The following is a description of a gene set: studied in species Homo sapiens Human Gene Set: E47_02 Genes having at least one occurrence of the motif NNNMRCAGGTGTTMNN in the regions spanning 4 kb centered on their transcription starting sites. This matches the TCF3 transcription factor binding site V$E47_02 (v7.4 TRANSFAC)., and this is the list of marker genes: NUMBL, HNF1B, MID1IP1, LYL1, CEL, MIEN1, BCL9, ERBB3, MGAT1, TPM2, MEF2C, GLI1, TICAM1, HDAC3, SLC7A11, PCDHA6, ERG, KLHL13, TMEM131L, ASIC4, FRMD5, MEIS2, SLITRK3, SNCAIP, RIMS2, PDE4B, PRKCQ, GNA12, TAL1, RAB33A, MYO18A, NPTX2 (NCBI Gene Id 95714), DRD3, CTDNEP1, DSCAML1, BICDL1, PCDHA10, PODXL, ZNF516-DT, NCDN, MLLT6, FOXI1, AIG1, MYL11, C6orf62, DMPK, NGFR, CPB1, AFF3, USP46, KCNN2, BCL2L1, ZNF532, SLC9A7, NDUFAF3, WDR6, CAVIN2, HMGN2, YIPF6, MAPK12, GIT1, MEF2D, MRTFA, ELAVL2, CNTN5, ASIC2, BZW2, S1PR1, CNTN6, OR10J1, RAPGEFL1, DENND1B, UBXN10, LSR, MMP16, KCNA4, AP4S1 (NCBI Gene Id 11154), MED26, HDAC9, PADI4, TTN, TENT5C, CPNE1, BTBD3, CELF4, TRAM1, THRA, PCM1, MEGF8, FGF11, NPAS2, PPTC7, APOBEC4, JMJD1C, PLEKHB1, LRRN3, GABRE, ESRP2, IRF1, RWDD2A, ARID5A, HES6, FGD4, NAA15, SYTL2, RHOBTB1, LMO2, GATM, WDR81 (NCBI Gene Id 780925), CUEDC1, EHD4, TPI1, CD40LG, FAM83H, BNC2, ARHGAP44, PTCHD1, MPPED2, ASXL2, DALRD3, GALR3, HSPB3 (NCBI Gene Id 8988), PURA, PNMA1, ARSG, GRIA1, SHISA7, HAPLN2, HOXA7, PPP2R2B, ABTB3, DUSP9, DGKA, FGF13, CCN3, ELP5, KMT2E, AMPH, KLHL1, PYM1, ART1, RELL2, CDH7 (cadherin 7), CHD6, FUT8, PARD6A, ZNF710 (NCBI Gene Id 374655), SEMA4G, TRAPPC13, TNFSF13, TSSK2, TTC22, PGM3, DSCAM, EPHB6, ARMCX2, CARTPT, STRN3 (NCBI Gene Id 29971), CEP41, NPAS4, R3HDM1, FRMD4A, STK3, NSG2, ALX3, SHOX2, ATOH7, WFIKKN2, PSMD3 (NCBI Gene Id 94019), PCYOX1L, PCDH17, CHRNB1 (cholinergic receptor nicotinic beta 1 subunit), PCDHA1, TRIM23, POU2AF1, FCMR, SNAP25, EGLN1, ABR (NCBI Gene Id 82701), GFAP, SYNE2, IKZF2, TEAD2, CELF1, PLPP7, SEPTIN4, ADAM12, TRERF1, PCSK4, RBM26, ZNF503, LRRN1, POU3F2, IDE, NOL4, C12orf42, LUC7L (NCBI Gene Id 57202), TFAP2A, TLNRD1, MYC, SASH1, AKT2, DDAH1, KLK1, CDK14, TSPAN33, DMD, NDUFS4, OFCC1, LRTM1, CASKIN2, EDEM3, ASB5, DNAH17, DOC2B, TMEM100, BAZ2A, SCN5A, JPH3, TSEN54, MYOCD, CHRM1, UNC5B, PRELP, CALB1, DDAH2, IRX4, HMCN1 (NCBI Gene Id 83872), WNT10B, ANXA8 (NCBI Gene Id 653145), HIVEP3 (HIVEP zinc finger 3), GJA4, NR2F6, PLEC, RUSC1-AS1, FOXA1, BMX, RBFOX1, BMF, TMEM35A, MXD1, TRIB2, STC2, COL22A1, SERPINI2 (NCBI Gene Id 5276), RRM2B, VWA2, ARL4A, USP54, NABP2, RASL10B, HSD3B7, SOX12, GSE1